Given this list of marker genes GOLGA2, CNIH2, CTSZ (NCBI Gene Id 1522), SEC22B, TMED10, TAP2, TMED3, LMAN1, ERGIC3, GRIA1, SPPL3, LMAN2, CALR, RAB1B, ROBO1, UVRAG, GOSR2, AZIN2, PRRG4, KDELR1, TGFA, F8, GALNT1, CD55, F5, INS, PALS1, VMP1, GORASP1, CSNK1D, STX17, ERGIC1, TMED1, YIF1B, SURF4, CD59, TMED5, TRIP11, YIF1A, STX5, AREG, SLC35C2, NAT8, TM6SF2, STING1, CNIH3, SERPINA1, CTSC, NAT8B, VPS13B, ASPSCR1, CNIH1, BCAP31, TBC1D20, DCSTAMP, RAB2A, VMA21, ERGIC2, TAP1 (transporter 1, ATP binding cassette subfamily B member), FOLR1, WHAMM (NCBI Gene Id 123720), MGAT1, COL7A1, ATP6AP1, TMED9, MCFD2, LAMP5, LMAN1L, CLN8, PLPP3, YKT6, TAPBP, TMED2, ZDHHC9, BET1, ZDHHC20 (zinc finger DHHC-type palmitoyltransferase 20), MPPE1, PIEZO1, TMED7, TMEM199, COPZ2, here is a description of the gene set: Human Gene Set: GOCC_ENDOPLASMIC_RETICULUM_GOLGI_INTERMEDIATE_COMPARTMENT_MEMBRANE The lipid bilayer surrounding any of the compartments of the endoplasmic reticulum (ER)-Golgi intermediate compartment system. studied in species Homo sapiens